Given this list of marker genes POLR3A, HERC1, GABRA3, FLNA, EBP, ATP7A, EYA1, RNU4-2, here is a description of the gene set: Long neck Human Gene Set: HP_LONG_NECK studied in species Homo sapiens Increased inferior-superior length of the neck.